Given this list of marker genes H2-Eb1, Rpl13a, Tnfaip8, Cst3 (cystatin C), Rps10, Sp140, Unc119, Gabarap, Gimap7, Gpx4, Rps15a-ps4, Ccl5, Ahnak, Fcgr2b, Rps27, Selenow (selenoprotein W), Lgals1, Gimap4, H2-Oa, S100a9, Cd44, Rbm3, Tpt1, Snhg18, Fam3c, Jun, Pdlim1, Mzb1, Cirbp, Rpl38, Capg, Cd2, Rsrp1, H2-K1, Txndc5, S100a8, Dnajc7, Itm2b (NCBI Gene Id 214227), Nap1l1, Mrpl52, Cd81, H2-Ab1, Lat2, H2-Q4, Prr13, Itgb7, Emp3, Gapdh, Ifi30, Pld4, Gns, Cybb, Sh3bgrl3, Jchain, H2-DMb1, Grb2, Pycard, Pfdn5, Crip1, Sh3glb1, Stx7, Sec61g, Rps21, Itm2c, Itgb1, Tcf4, Sat1, Rabac1, Use1, H2-D1, Irf8, Ptpn1, Evi2a, H2-Aa, Sp140l1, Psap, Npc2, H2-T23, Cd72, Tspo, Scimp, AW112010, B2m, Ctsh, Psmb9, Lime1, Sp140l2, Fos, Ly6a, Apoe, Bcl2a1b, Srgn, Txn1, Syk, Akr1a1, Gimap3, Psmb8, Zbtb20, Fxyd5, Ptpn18, Cyp4f18, here is a description of the gene set: from publication Tabula Muris Consortium (PMID 32669714) studied in species Mus musculus Mouse Gene Set: TABULA_MURIS_SENIS_SPLEEN_B_CELL_AGEING